The following is a description of a gene set: species: Mus musculus Mouse Gene Set: GOBP_POSITIVE_REGULATION_OF_CELL_PROLIFERATION_INVOLVED_IN_KIDNEY_DEVELOPMENT Any process that activates or increases the frequency, rate or extent of cell proliferation involved in kidney development., and this is the list of marker genes: Serpinb7, Il6ra, Pdgfb, Itgb3, C3ar1, Lin28a, Pdgfd, Myc, Egr1, Cflar